The following is a description of a gene set: studied in species Homo sapiens Human Gene Set: GOBP_NEURONAL_ACTION_POTENTIAL An action potential that occurs in a neuron., and this is the list of marker genes: GPER1, SCN4B, GLRA1, MTNR1B, DRD1, GPR88 (G protein-coupled receptor 88), HCN1, ASIC5, GRIA1, ANK3, KCNMB4, SCN11A, TRPA1, KCNK2, KCNQ3, KCNA1, GJD2, KCNA2, CHRNA1, SCN1A, KCNMB2, SCN2A, GRIK2, KCNK4, GPRIN3, GBA1, P2RX1, BBS10, CACNA1I, NPR2, MTOR, SOD1, SCN9A, FGF12, KCNMB3, CHRNB4, MYH14, KCND2, FMR1